The following is a description of a gene set: Mouse Gene Set: GOMF_PIRNA_BINDING studied in species Mus musculus Binding to a piRNA, a Piwi-associated RNA, a 24- to 30-nucleotide RNA derived from repeat or complex DNA sequence elements and processed by a Dicer-independent mechanism., and this is the list of marker genes: Cnot7, Piwil2, Mov10l1, Piwil1, Hnrnpu, Tex19.1, Piwil4, Tex19.2